Given this list of marker genes AGER, RELA, NFKB2, RIGI, TRAF6, CHUK, NKIRAS2, S100B, TRIM25, IKBKB, TRAF2, NFKBIA, SAA1, TRIM4, MAVS, NFKB1 (NCBI Gene Id 4790), MAP3K1, APP, IFIH1, HMGB1, RNF135, IKBKG, NFKBIB, S100A12, NKIRAS1, here is a description of the gene set: TRAF6 mediated NF-kB activation studied in species Homo sapiens Human Gene Set: REACTOME_TRAF6_MEDIATED_NF_KB_ACTIVATION